The following is a description of a gene set: species: Homo sapiens Genes in the cancer module 539. Human Gene Set: MODULE_539, and this is the list of marker genes: FUT1, GYPC, ALAS2, GYPA, UROD, RHAG, PPOX, GYPE, RHD, CP, CPOX, KEL, GYPB, FECH, HMBS, UROS